The following is a description of a gene set: studied in species Mus musculus The process that mediates interactions between a bundle of His cell and its surroundings that contributes to the process of the bundle of His cell communicating with a Purkinje myocyte in cardiac conduction. Encompasses interactions such as signaling or attachment between one cell and another cell, between a cell and an extracellular matrix, or between a cell and any other aspect of its environment. Mouse Gene Set: GOBP_BUNDLE_OF_HIS_CELL_TO_PURKINJE_MYOCYTE_COMMUNICATION, and this is the list of marker genes: Kcna5, Rangrf, Dsg2, Dsc2, Tnni3k, Trpm4, Tbx5, Gja5, Scn10a, Scn5a, Cacna2d1, Ctnna3, Dsp, Jup, Pkp2